The following is a description of a gene set: Mouse Gene Set: GOBP_SECRETION_OF_LYSOSOMAL_ENZYMES species: Mus musculus The controlled release of lysosomal enzymes by a cell., and this is the list of marker genes: Hps1 (NCBI Gene Id 54334), Idua, Gnptab, Bloc1s6, Nagpa, Nr1h3, Lyst, Bloc1s3, Nr1h2, M6pr